Given this list of marker genes Dhx9, Khdrbs1, Cpsf6, Nrde2, Ncbp2, here is a description of the gene set: studied in species Mus musculus Any process that activates or increases the frequency, rate or extent of directed movement of RNA from the nucleus into the cytoplasm. Mouse Gene Set: GOBP_POSITIVE_REGULATION_OF_RNA_EXPORT_FROM_NUCLEUS